The following is a description of a gene set: from publication Yevshin I, Sharipov R, Kolmykov S, Kondrakhin Y, Kolpakov F (PMID 30445619) Human Gene Set: ARHGAP35_TARGET_GENES species: Homo sapiens Genes containing one or more binding sites for (ARHGAP35) in their promoter regions (TSS -1000,+100 bp) as identified by GTRD version 20.06 ChIP-seq harmonization., and this is the list of marker genes: MICOS10-NBL1, AKAP11, RBPJ, CBX3, ERGIC2, ATG4B, TMEM18, BTBD10, RNU5F-1, EGLN3, GPR137, MICOS10, RNVU1-28, RBM39, ERCC6L2, ENSG00000267260, FBXL5, SNORD13, CHAF1A, TMEM209, SLC12A2-DT, RNU11, RNU5E-6P, MICOS10-DT, RPL12, PTPN4, LINC02281, PPP4R3B, RPL17-C18orf32, PURA, SNORD118, SNORD58B, STRIP1, DERL2, ENSG00000273727, LUC7L2, TUBGCP5, MRPL57, MARCHF7, GFI1B, RPL17, COX11, PPP4R3B-DT, ERCC6L2-AS1 (ERCC6L2 antisense RNA 1), DENR, STYXL1, DAZAP1, IREB2, GRK4 (NCBI Gene Id 2868), CIAPIN1, DAGLA, SQSTM1, SKA3 (spindle and kinetochore associated complex subunit 3), DBR1, SCAMP5, RNVU1-25, RNVU1-4, SLC12A2, MTMR8 (myotubularin related protein 8), HNRNPA2B1, GPATCH3, HSD17B6, FCMR, CDK12, UHRF2 (NCBI Gene Id 49857), QRICH1, NCOA4, ANKFY1, MAP2K2, PLEC, MBTPS1, ZNF850, SLC25A11, TSPYL6, RNVU1-3, PKIB, RNVU1-26 (RNA, variant U1 small nuclear 26), PLEKHG4, RAD51D, TAOK1, LINC02327, PRDX1, UBE2I, DCAF16, RNVU1-6, TTI2, COASY, ARF3, STXBP4, FAM135A, SEC63, LINC01719, EIF5, DCHS1, LRSAM1, FAM200B, SLC25A4, RNVU1-15, RNVU1-19, PSMD5, NCAPG, MBTPS1-DT, FHL1P1, RPS7, ASXL1 (NCBI Gene Id 23393), CUL3, MDH2, SEC62, SPPL3, RPS19, RNU4-1 (RNA, U4 small nuclear 1), POU2F3, RNF167, RPS6, NOP14, NOP53-AS1, LTBP3, TIPIN, COQ9